Given this list of marker genes ABCA12, GPS2, PPARG, MIR26A1, TMEM97, MIR302A, ANXA2P2 (annexin A2 pseudogene 2), CETP, PTCH1, NUS1, APOC2 (NCBI Gene Id 344), MIR33B, NFKBIA, MIR27B (microRNA 27b), OSBPL6, APOA1, ABCG1, COMMD1, EGF, MIR17, MIR758, ABCB4, ABCA13, NR1H2, ABCA8, SREBF2, LIPG, SIRT1, NFKB1, ARV1, APOC3, TTC39B, MIR33A, MIR206, MIR145, LAMTOR1, MIR93, MIR148A, PLA2G10, SEC24A, CES1, MIR144, ABCG4, YJEFN3, ABCA3, LDLRAP1, MIR128-1, CAV1, MIR27A, PCSK9, MIR9-1, NAXE, ABCA5, MIR301B, APOA2, APOC1, SHH, APOE, FURIN, APOA4, TSPO, ABCA7, ABCA1, TREM2, RXRA, LRP1, MIR19B1, PON1, MIR185, ADIPOQ, MIR613, MAPK3, SCP2, PLTP, ANXA2, ABCA2, MIR130B, ZDHHC8, NR1H3, EEPD1, here is a description of the gene set: Human Gene Set: GOBP_REGULATION_OF_STEROL_TRANSPORT Any process that modulates the frequency, rate or extent of the directed movement of sterols into, out of or within a cell, or between cells, by means of some agent such as a transporter or pore. species: Homo sapiens